The following is a description of a gene set: species: Mus musculus Mouse Gene Set: YAO_TEMPORAL_RESPONSE_TO_PROGESTERONE_CLUSTER_16 Human infertility and recurrent pregnancy loss caused by implantation defects are poorly understood. Hoxa-10-deficient female mice have severe infertility and recurrent pregnancy loss due to defective uterine implantation. Gene expression profiling experiments reveal that Hoxa-10 is an important regulator of two critical events in implantation: stromal cell proliferation and local immunosuppression. At the time of implantation, Hoxa-10 mediates the progesterone-stimulated proliferation of uterine stromal cells. Hoxa-10 mutants express a stromal cell proliferation defect that is accompanied by quantitative or spatial alterations in the expression of two cyclin-dependent kinase inhibitor genes, p57 and p15. Hoxa-10 deficiency also leads to a severe local immunological disturbance, characterized by a polyclonal proliferation of T cells, that occurs in place of the normal progesterone-mediated immunosuppression in the periimplantation uterus. from publication Yao MW, Lim H, Schust DJ, Choe SE, Farago A, Ding Y, Michaud S, Church GM, Maas RL (PMID 12554760) Genes co-regulated in uterus during a time course response to progesterone: SOM cluster 16., and this is the list of marker genes: Col18a1, Tubb4a, Pcp4l1, Fez1, Trp53 (transformation related protein 53), Tfpi, Idi1, Gusb, Ndp, Npnt, Fabp5, P3h3, Dmpk, Hnrnpdl, Aqp4, Col1a1, Mrps25, Actc1, Nme4, Akt1s1, Agr2, Dab2, Crtap, Pygm, Pcdh7, Col6a2, Cavin3, Bzw2 (NCBI Gene Id 66912), Rexo2, D17H6S56E-5, Fads1, Ptger3, Clvs1, Tnni2, Calm3, Anxa6, Fez2, Npdc1 (NCBI Gene Id 98898), Pcolce (NCBI Gene Id 18542), Nptx2, Gpx7 (glutathione peroxidase 7), Sparc, Kdelr3, Pfn2, Dbn1, Fbn1, Aoc3, Cyp51, Praf2, Mfap2, Stra6, Igfbp5, Crabp1, Vcan, Col4a1, Pdlim7, Cnn1, Msmo1, Srpx, Sh3bgr, C1qtnf12, Smoc2, Sqle, Igkv15-103, Col3a1, Col1a2, Maoa, Tmem45a, Col6a3, Colgalt1, Tnnt2, Actn1, Bgn, Sardh (sarcosine dehydrogenase), Gapdh, Mest, Wdr6, Adam15, Bcl7c, Col4a2